Given this list of marker genes Ankfy1, Vti1a, Ap4m1 (NCBI Gene Id 71646), Vti1b, Ap3s2, Laptm5, Ap1g1, Ap3d1, Vps54, Vps29, Sort1, Ccdc91, Lamp1, Rbsn, Vps52, Cln3, Ehd3, Ap3s1, Ap1g2, Gak, here is a description of the gene set: Mouse Gene Set: GOBP_GOLGI_TO_VACUOLE_TRANSPORT studied in species Mus musculus The directed movement of substances from the Golgi to the vacuole.